The following is a description of a gene set: Human Gene Set: GOBP_OUTER_DYNEIN_ARM_ASSEMBLY species: Homo sapiens The aggregation, arrangement and bonding together of a set of components to form an axonemal dynein outer arm, an outer arm structure present on the outer doublet microtubules of ciliary and flagellar axonemes., and this is the list of marker genes: DAW1, DNAH8, ODAD2, DNAAF2, ODAD4, DNAI1, DNAAF5, DNAAF6 (NCBI Gene Id 139212), CCDC103, DNAH5, DNAAF8, LRRC61, DNAAF1, CCDC63, ODAD3, DNAI2, DNAAF4, CLXN, DNAH17, ZMYND10, DNAL1, ODAD1, DNAAF11